The following is a description of a gene set: Mouse Gene Set: GOBP_DICARBOXYLIC_ACID_METABOLIC_PROCESS The chemical reactions and pathways involving dicarboxylic acids, any organic acid containing two carboxyl (COOH) groups or anions (COO-). studied in species Mus musculus, and this is the list of marker genes: D2hgdh, Gls2, Glud1, Htt, Fahd1 (fumarylacetoacetate hydrolase domain containing 1), Amdhd1 (NCBI Gene Id 71761), Got1l1, Fh1, Gad2, Aasdhppt, Pck2, Adhfe1, Me3, Gclc, Nit2, Shmt1 (serine hydroxymethyltransferase 1 (soluble)), Acmsd, Atcay, Col6a1, Mdh2, Apc, Reg3g, Dlst, Aldh1l2, Ogdh, Idh2, Acot8, Slc25a12, Rac1, Mdh1b, Folr1, Mrps36, Got2, Acly, Bin1 (NCBI Gene Id 30948), Gad1, Mthfd2l, Bcl10, Acot4, Grhpr, Pm20d2, Sdhaf3, Dglucy, Pcx, Hoga1, Suclg1, Haao, Phyh, Idh1, Fahd2a, Aldh18a1, Mthfsl, Aldh4a1, Kmo, Got1, Gls, Cs, Aldh1l1, Gpt2, Lipf, Adss2, Kyat3, Gclm, Atic, Slc38a8, Glul, Dhfr, Extl3, Mdh1, Me2, Aspa, E2f1, Ass1, Ddo, Mthfd1l, Aadat, Nat8l, Fpgs, Ggt1, Ido1, Xiap, Dld, Prodh2, Tat, Aldh5a1, Asl, Acsf3, Adss1, Ogdhl, Bloc1s6, Oat, Qprt, Nags, Suclg2, Uroc1, Sdhb, Pck1, Prodh, Sdha, Hal, Me1, Csl, Ftcd, Sucla2, Kynu, Nr1h4, Slc7a11, Mthfd1, Mtrr